Given this list of marker genes Dleu2, Frg2f1 (NCBI Gene Id 433752), Ccdc159 (coiled-coil domain containing 159), Cetn2, Mir24-2 (microRNA 24-2), Tmem80, Cd164 (CD164 antigen), Zfp580, Dnajc10, Map3k7, Wdr70, Zfyve27, Kxd1 (NCBI Gene Id 97450), Oip5, 4933433G15Rik, Wdr25, Casp4, Atp6v0a4, Tex10, Pcyox1l, Neu2, Hpn, 2010016I18Rik, Ovca2, mt-Tn, Sac3d1, Adgrb1, Hnrnpul1, Gm37294, Kmt5c, Mob3b, Cd69, Kmt2c, Rela, Gm2453, Wdr77, Inpp5a, Bltp2, Zfp948, Axin2, Ifngr2, 0610038B21Rik, Rnf139, Map3k8, Kel, Gm25721, Dchs1, Kif23, Thap1, Adam5, Mrps18c, Pih1d1, Foxp1, Pigw, Gramd1a, Setd5, Nfam1, Ndufb9, Psme2, Fam221a, Rbck1, Rc3h1, Hadha, Stag3, Junb, Snhg8, Nox1, Cish, Msh3, Nlrp3, Selenok, 2010106C02Rik, Atp5f1c, Grk4, mt-Nd2, Anxa5, Tet2, Tbc1d1, Runx1, Plp2, Akr1b8, Pcdh7, Mir9-2, Odr4, Cdk5rap1, Ccdc66, Mir5130, Trp53, Tanc2, Usp19, mt-Tl1, Srebf1, Gm14656, Vps35l, Grin1, Laptm4b, 1700066M21Rik, Prex1, Smim5, Plekhg1, Arhgap10, 1700084C06Rik, Cebpg, Mmel1, Pax7, D230022J07Rik, Gm11788, B3galnt2, Arhgef10l, Myl4, Adh6b, Mgarp, Yy1, Mrpl44 (mitochondrial ribosomal protein L44), Mxd1, Irf2, Dennd4b, Hirip3, Smc4, Ccdc71, Gm8066, Hsd3b7, Nomo1, Tmem38a, Haus2, Pusl1, Mylip, Rsu1, Chpt1, B4galt6, Slc30a7, Abl1, Cnih4 (cornichon family AMPA receptor auxiliary protein 4), Pik3r5 (NCBI Gene Id 320207), Nsun6, Nfil3, Stk11ip, Gm22148, 5830454E08Rik, Ilk, Gtf2i, Fam110a, Gm26419, Gm10605, Rab28, Cfap126, Hivep1, Smg1, Sh2b3, Wiz, Cystm1, Sf3b1, Odf2, Tmem168, E2f3, Gripap1, Kcnab1, Gm12764, Nkx1-2, Atxn2l, Vim, Zbtb26, Barhl1, Dab2, Zmiz2 (zinc finger, MIZ-type containing 2), Slf2, Lrrfip1, Fcrl5, Pop1, Nek11, Jak2, Bod1l (biorientation of chromosomes in cell division 1-like), 0610043K17Rik, Fbxo46, Pigv, mt-Th, Nme5 (NCBI Gene Id 75533), Hspb7, Usp49, Snord55, Mif4gd, Rock1, Csrnp1, Rrp1b, Fubp3, Ankrd13a, Scrn3, Kmt5b, Ppie, Dgkz, Gna15, Pomt1, Adgre1, Ccl9, Wrap53, Stk10, 2410006H16Rik (NCBI Gene Id 69221), Gm15283, Xntrpc, 4933405D12Rik, Katna1, Rasa1, Fam20c, Slc49a4, Nkapd1, Paxip1, Chfr, Stau1, Bcl2l1, Ttc39b, Taf3 (TATA-box binding protein associated factor 3), Hsp90ab1, Ripk2, Afg3l1, Plec, mt-Tq, Atl2, Ddx1, Ccl5, Ppp1r21, Gm11527, Rras, Lxn, Rbm4b, Gm5475, Il16, mt-Co2, Cct4, Gosr2, Wt1, Slc39a4, Cul1, Ascc3, Gm6410, Gm26756, Ptges, Dcun1d4, Efcab14, Pabpc1 (NCBI Gene Id 18458), Hexb, Mfsd13b, Nab1, Etv1, Pced1a, mt-Ty, C3, Rdx, Ubxn2a, Ccr3, Arpin, Mdm4, Gm2673, Pnrc1, Cep120, Nod2, Ahctf1, Nmd3, Mnt, Iscu, Dedd, A630072M18Rik, Mir9-2hg, Plcg2, Inpp5k, Rn7s6, Nfkbiz, AA386476, Tmem164, Mri1, Prelid3a, Ctdspl2 (NCBI Gene Id 51895), Prr12, Pigg, Adam9, Prmt5, Nsl1 (NCBI Gene Id 98359), Gorasp2, Hipk3, Ift81, Rab40c, Armc10, Mapre2, Hyal2 (hyaluronoglucosaminidase 2), Ddx5, Agk, Sall2, Satb2, Pea15a, Dusp13b, Zfp367, Gm12508, Zfp429, Arhgef1, Chchd1, Irf1, Serf2, D2hgdh, Map7d1, Sufu, Pwwp2a, Gm11476, Parp4, Traf3, Snora24, 2900052L18Rik, Sqle, Zfp593, Fndc4, Or6c208, Rasgrp4, Gm10699, mt-Ta, Ddhd1, Slc30a1, Capg, Sirt2, Lasp1, Cep68, Pa2g4, Gpr155, Il1rn, Fermt1, Scp2, Eif1ad, Acot7, Gm10575, Sfi1, Tec, Agps, Cyp4v3, Il2rg, Mir7653, Sertad2, Rps12l1, Gm15290, Nr3c1, Tex264, Zbtb21, Zkscan17, Armc9, Cnksr3, Uap1, Arap1 (NCBI Gene Id 69710), Tfe3, Stard10 (StAR related lipid transfer domain containing 10), Slain2, Pag1, S100a10, Zranb3, Tm2d2, Rap2c, mt-Ti, Il3ra, Gm7461, Pnrc2, Ankrd33b, Gatad1, Efcab9, Sirt6, Ccny, Gpr19, 4930558J18Rik, AA474408, Lgals8, 1700055D18Rik, Nptn, Wdr4, Sdc4, Rhog, Cntnap1, Rarg, Igkv13-84, Alcam, Tnip1, Rlf, Cdc20, Serhl, Als2cl, Slc25a10, Flvcr1, Gm2566, Ggnbp2, Htra2, Pgap3, Togaram2, Chd7, Ing2, Sys1, Vwa8, Necap2, Larp1b, Grk2, Ctnna3, Smad2, Ralgds, Rpsa, Gpd2, Mir193a, Sucnr1, Gm16527, Zcchc4, Tnfsf13b, Slc1a2, Dym, Ttc33, Ttc9c, Btd, Tradd, Nrbf2, Tagap, Nfyc, Aff1, Ino80e, 1110020A21Rik, Cd44, Ago1, Rimklb, Nfkbie, Gnb1, mt-Tl2 (mitochondrially encoded tRNA leucine 2), Saxo2, Atg10, Gm12791, Ppp1r37, Lacc1 (laccase domain containing 1), Baz1b, Creld2, Ctu2, Map2k2, Epb42, Itpkc, Endod1, Gpr132, Slc35a3, Cds1, Traf1, Tmed1, Rab11fip5, Actr3, Ddx55, Ascc2, Ssb, Mms19, Ugcg, Ifrd1, Gipc1, Eif4a1, Birc3, 1810053B23Rik, Itga2b, Pou2f1, Ccdc6, Ssh2, Tmem135, Jph4, Twf2, Map1b, Ubp1, Arhgef2, Gpbp1, Irgm1, Cdk14, Tcirg1, Rabgap1, Clock, 4632411P08Rik, Tbck, Snd1, Kansl1, Tpr (translocated promoter region, nuclear basket protein), Uspl1 (NCBI Gene Id 231915), Sdhc, Grsf1, Resp18, Arfgap3, Ints12, Ccl3, Rps27l, Nusap1, Hbp1, Trappc8, Cdc42, 4933439C10Rik, Smoc1, Rdm1, Foxd2os, Abcb6, Akr1c12 (aldo-keto reductase family 1, member C12), Gm5106, Rpl22, Tigd2, Ctsa, Boll, Tnfaip3, Dut, Actrt3, Rpa2, Hnrnpa2b1 (heterogeneous nuclear ribonucleoprotein A2/B1), Myo19, Hadhb, Zbtb6, Pcid2, Pik3r1, Gpr85 (NCBI Gene Id 72866), Ranbp10, Snord49a, Zmiz1os1, Cfap77, Clec4a1, 1810037I17Rik, Dusp3, Rpl14-ps1, Ank1 (NCBI Gene Id 11733), Zbtb25, Rmrp, Ttc17, Enc1, Apba3, B2m, Bin1, Rcbtb2, Ptprj, Zeb1 (zinc finger E-box binding homeobox 1), Rgl1, Grk5, Camkk2, Nfkbid (NCBI Gene Id 243910), Akt2, Wee1, Adcy7, Srcap, Rsl1, Cebpa, Elf2, Gm16016, Golm1, Ehd1 (NCBI Gene Id 13660), Tor1aip1, Gm25541, Stom, 1700108F19Rik, Ttc19, Slc15a3, H2-T22, Map3k12, Asns, Gm14692, Sms, Rhoc, Bach1, Slc11a1, Rhoa, Bnip3, Hspbap1, Slamf9, Nup205, Ppm1g (protein phosphatase 1G (formerly 2C), magnesium-dependent, gamma isoform), Usp15, Jpt1, Pbx3, Gm12500, 9130017K11Rik, Erc1, Sfr1, Furin, 5430400D12Rik, Frmd4b, Dennd4a, Gm15663, Pafah1b3, Cenpo, Mir5131, Itga4, Asxl1, Mllt6, Atox1, 4930412F09Rik, Zc3h12c, Ube2d3, Ccdc122, Coq8a, Sugt1, Fchsd2, Pwwp2b, Spaca6, Zfp40, Gm10244, Lzts2, Cbx8, Txn2, Gm12509, Zc3h10, Klc4, Mir1938, Atp6v1b2, Ebi3, 2310010J17Rik, Sfpq, Zfp768, Hjurp, Capzb, E130102H24Rik, Lgr4, Lancl2, Caprin1, Gatd1, Artn, Luzp1, Urah, Gm15880, Dbp, Upp1, Smarcd3, Gm15559, Lpin2, Fam3c, Jdp2, Akt3, Cxcl11, Rrad, Cul3, Itga5, Calcr, Sema4d, Edem3, Xbp1, Rel, Atpaf2, Dusp2, Mir449c, Capn7, Ago3, Brat1, Phip, Oas1h, Ntan1, Notch2, Ramac, Epb41, Sdc1, Gm15545, Psmf1, Il6st, Jade2, Mis18bp1, Trbv12-1, Rhbdd2, Degs1, Edf1, St7, Relb (avian reticuloendotheliosis viral (v-rel) oncogene related B), Prickle3, Rab11fip4, Hspa5, Eif4h, Nfx1, Gm9889 (NCBI Gene Id 791369), Gbp5, Slc29a2, A530072M11Rik, Picalm, Iqch, Mtmr6, Sde2, Gm14703, Amz2 (NCBI Gene Id 13929), Ubac2, Nme1, Zbtb7b, Ptgr2, Foxh1, Tlr2, Gstcd, Nrf1, Msh6, Pax6, Tmem184b, Ier2, Gm19721, D930030I03Rik, 1810062G17Rik, Pierce2, Meig1, Dtnb, 2310044K18Rik, Pacc1 (proton activated chloride channel 1), Tra2a, Cux1, Tatdn1, Apobr, Yipf3, Mmp9, Pacsin2, Tiparp, Gm16712, Wrnip1, Taok3, Cimap1b, Cimap2, Csnk1g1, Srgap2, Sp100, Ppt1, Niban2, Dhfr, Zc3h12a, Nsdhl, Wdtc1, Aste1, Hip1r, Creb1, Fmo4, Gm11769, Zfp143, Fhad1, Slc12a4, Cdh4 (cadherin 4), Dock6 (NCBI Gene Id 76780), Rad18, Mrps22, Zmynd12, Rnf121, Rrp8, Eef1b2, Cxcl1, Gm7008, Gm22675 (NCBI Gene Id 115489578), Echs1, Bmi1, Fau-ps2, 4732471J01Rik, Sart3, mt-Tw, Rspry1 (NCBI Gene Id 67610), Synpo, Tsn, Aldh16a1, 1700058P15Rik, Neil2, Gm14455, Insyn2b, Or8b8, Pdss1, 9130230L23Rik (RIKEN cDNA 9130230L23 gene), Nr2f6, Aagab, Ern1, Cxcl10, Akap10, Cnot10, mt-Td, Mars1, Six5, Golga5, Capza2, Moap1, Zfp280d, Jpx, Tsc22d4, Hnrnph3, Polr1c, Slc25a19, Ube2q1, Mov10, Kat8, Nfkbib, Phldb1 (pleckstrin homology like domain, family B, member 1), Prkar1a, Or7g31, 2010320M18Rik, Acp5, Tm9sf3, Arid1a, Cd151, Prkacb, Eva1b, Far1, Clta, Mlc1 (NCBI Gene Id 170790), Esyt2, Gm22813, Vapa, Slc25a54, Arl5c, Tob2, Ifrd2, Mir210, Nudt9, Gm4189, Atf7ip, Brd9, Nadk (NAD kinase), Ppp3ca, Pias3, Il27ra, Dclre1c, Sema4a, Poglut1, Cep95, Atrip, Kifc3, Mir762, Ccr10, Ufl1, Rps2, Acap3, Exd1, C330022C24Rik, Ddx54, Ccdc107, Dusp5, Samd4, Gbp6, Utp3, Zbtb3, Usp25, Gm29257, S1pr1, Ubl7, Map4, Gpd1l, Fosl2, Rps8, Bbc3, BC049739, Troap, Chrac1, Wdr26, Zbtb10, Ube2h, Prkcd, Asb1, Aup1, Polr2a, Rad54l2, Arhgap12, Map4k4, Hmgb1, Epas1 (NCBI Gene Id 13819), Zfp1006, Cd83, Tmie, Cdk12, Tbc1d22b, Pwp1, Pik3r2, Denr, Glt8d2, Ampd3, Morf4l1, Pus3, Flywch2, Cdc14a, Tmcc1, Ptpn3, mt-Tm, BC005537, 4930515G01Rik (RIKEN cDNA 4930515G01 gene), Tnip3, Tsc1, Srd5a3, Sik3, Krt19, Ulbp3, Rnf38, Sesn2, Gm7467, Mir6236, Arhgef19, Eif1b, H4c1, Gm24524, Rapgef1, Tsnax, Bmal1, Sh3glb1, Birc5, Capn5, Tpk1, Cyp7a1, Cdc20b, Ift80, Trappc3, Afg1l, Alas1, Rps5, Wars1, Akap7, Lrp11, Slc39a13, Thnsl1, Mir7075, Gm26330, Gpr84, Nenf, Snora64, Olfr1235-ps1, Tmco6, Bpi, Ptrhd1, Rgs19, Ptprs, Cnrip1, 1700066B17Rik, Atp9b, Elp1, Enoph1, Zic4, Gm13610, Tas2r140, Kctd12, R3hdm1, Wdfy1, Mllt1, Ppp2r3a, Gm43838, Irf5, Naa10, Stk11, Ccr9 (C-C motif chemokine receptor 9), Ccpg1, Ddx59, Tnfaip2, Pja2, Ubr4, Trim29, Gt(ROSA)26Sor, Crybg3, Mrpl17, Snord49b, Milr1, 1810021B22Rik, Gm15411, Sfswap, Aimp1, Gm15972, Mgat4a, Adck1, Stxbp1, Itgb5, Ampd2, Rita1, Pycard, Stx11, Stat3, Rnaseh2b (NCBI Gene Id 68517), Mkrn1, Gm15564, Ccdc9, Prkag1, Clk4, A930006K02Rik, Gbe1, C130046K22Rik, Hif1a, Acin1, Ipo5, Fuz, Ap2a2, Eps15, Unc119, Relt, Ptpn2, Zbtb1, Gfi1b, Gm13010, Tpbg, Rbm19, Usp42, Taco1, Klhdc8b, Il4ra, Ptpra, Bcl10, Prpf40a, Ppcs, Trmt10a, Zfp608, Ark2n, Hexa, Yipf2, Ypel5 (yippee like 5), 4930583K01Rik, Trabd, Gm12359, Flii, Sptan1, Atosa (NCBI Gene Id 70761), Ift88, Ino80d, Gm567, Mttp, Xiap, Sox6, Fzr1, Tnpo1, Ncoa4, Zfp800, Slc30a3, Pde4a, Jmjd1c, Manbal, 2810414N06Rik, Ndufv3, Tssk6, Or10ad1b, Grid2ip, Fbxl2, Zmym6, Esco1, Plekhf2, Rgs9, Bcorl1, Ccrl2, Gm9920, Memo1, Manba, Ubtd1, Ikbke, Mef2c (NCBI Gene Id 71350), Gm6283, Clpp, Gm16675, Erp29, Dclre1a, Gm11613, Polr2e, Rab6a, Dhx29, Snx5, Smpx, Abca1, Ctbp1, Gnb3, Gm24922, Ripor2, Setx, Tmem217, Trip4, Gm14221, Svil, Lmna, Mpc1 (mitochondrial pyruvate carrier 1), 1700113B19Rik, Sat2, Plau, Gpatch8, Gm11952, Neurl3 (NCBI Gene Id 76530), Gmeb1, Cd40, Terf2, 1700113A16Rik, Lyplal1, Ube2m, Nfe2l1, Micu1, Zfp287, Uck2, Nipsnap3b, Kpna4, Pde8a, Tor1aip2, Tufm, Ube2e3, Hmg20a, Csf1, Phf8, Gm26812, Nudt1 (NCBI Gene Id 17766), Frmpd3, Lmbrd1, Esrra, Tor4a, Rab34, Meis1, Xndc1, Gm4890, Nup153, Ticam2, Zdhhc15, Coasy, Nop14 (NCBI Gene Id 75416), Smad5, Zfp91, Sec24a, Tmem19, Herc3, Ube2e2, Prxl2c, Ltbr, Cbx3, mt-Nd1, Hgf, Nrp2, 2500004C02Rik (RIKEN cDNA 2500004C02 gene), Gm13270, Acox3 (NCBI Gene Id 80911, acyl-Coenzyme A oxidase 3, pristanoyl), Mrpl2, Pacsin3, Gm15850, Ino80dos, Dennd1a, Nlrp10, Rraga, Ppp4r3b, Mars2, Bloc1s1 (NCBI Gene Id 14533), Slc36a3os, Amfr, Nfatc1 (nuclear factor of activated T cells, cytoplasmic, calcineurin dependent 1), Stard9, Nvl, Ptar1, 4632428C04Rik, Adgrg6, Pfkfb4, Prdm4, Rab3ip, Arl6ip6, Gbp9, Nudt17, Tln1, Clic4, Rev3l, 9530034E10Rik, Csgalnact2, Etv5, N4bp2l1, Limd2, Smim7, Echdc3, Gm15417, Luc7l, Il27, Psme1, Sun2, C1qc, mt-Cytb, Emsy, Mydgf, Ifi30, Srrm2, Cox18, Rin2, Rrp9, Plppr2, Ap1s2, Skil, Tcf4, Mir425, Mir23a, Jup, Urb1 (NCBI Gene Id 76006), Cfp, Pnpla2 (patatin-like phospholipase domain containing 2), Cir1, Ist1, Gmcl1, Htra1, Sgo1, Helq, Nlk, Arfgef3, Pou2f2, Rida, Chp1, 1700088E04Rik, Dap, Arf4 (ADP-ribosylation factor 4), Kcnq5, Mmp2, Spice1, Lrrc57, Lrrk1, B3gntl1, Gnaq, Gnb2, Bhlhe40, Mtrex, Dnajc12, Mir27a, Tcea2, Gadd45b, Sec23b, Specc1, Slc17a5, Tlr9, Col18a1, Adora2b, Ppp6r1, Gin1, Ganc, Zbtb20, Dbn1 (NCBI Gene Id 56320), Rnf111, Bms1, Kif5c, Gclm, Pdlim5, 1700065D16Rik, Tsnaxip1, Pde4b, Nfkbia, Cdca7, Rad52, Cd70, Pkd2l1, Rps6 (ribosomal protein S6), Cntrl, Xpo6, Tsc22d1, Parp3, Septin9 (NCBI Gene Id 53860), Polr3e, Pcnx4, Pan3, Syncrip (synaptotagmin binding, cytoplasmic RNA interacting protein), Prkci, Gpx4, Tceal7, Aldoa, Azin1, Otud4, Cblb, Tmem87b, 2500002B13Rik, Mafa, N4bp3, Myh9, Mthfd1l, Raph1 (Ras association (RalGDS/AF-6) and pleckstrin homology domains 1), Arl5b, Nap1l4, Nfkb1, Cln3, Egln2, Mir7009, St6galnac6 (NCBI Gene Id 50935), H1f10, Cpsf4, Cacna1a, Rabgef1, Pheta1, Tank, Dhx9, Socs3, Kctd18, Sipa1l3, Sh3yl1, Ighv1-45, Zdhhc20, Tra2b, Nfkb2, Osm, Mcub, Rtel1, Bcl7c, Chd9, Kcp, Gm16685, Gm24393, Atp6ap2, Kat6a, Zzz3, Dennd10, Lrrc59 (leucine rich repeat containing 59), Mt1, mt-Tc, Atp2b1, Vamp4, Mrm1 (mitochondrial rRNA methyltransferase 1), Irak1bp1, Ankhd1, Dmtf1, Foxd2, Stau2, Rdh5, Spred1, Sin3a, Exosc7, Tgif1, Ep400 (E1A binding protein p400), Paqr3, Pfkfb2, Socs1 (NCBI Gene Id 12703), Chct1, Cnnm4, Uqcr11, Trip13, Vcan, Klhl25, Gm6658, Lrrc52, Cxcl2, Cfap44, Sod1, Rnf2, Gsdmd, Hnrnpdl, Fnbp4, Arid5a, Kbtbd2, Gm34086, 4632404H12Rik, Smarca2 (NCBI Gene Id 67155), Nr1d2, Chd2, Rcsd1, Slc44a3, Washc5, Nr1d1, Ifnar1 (interferon (alpha and beta) receptor 1, NCBI Gene Id 15975), Gm20652, Pgghg, Ntn1, Rfc1, Gm10602, Chordc1, Plk4, Srsf4, Mrpl12, Mir7011, Agap2, Pde4c, 4930539J05Rik, Psme3ip1, Snora78, AU016765, Haus1, Ptpn6, Cul4a, Klhl12, Atp5pb, Adrb2, 9130401M01Rik (RIKEN cDNA 9130401M01 gene), Irak2, Gas7, Fam20b (FAM20B, glycosaminoglycan xylosylkinase), Dvl1, Casc3, Pum2, Tmem116, Togaram1, Mad1l1, Pih1d2, Deaf1, Adamts17, Fmnl1, Tspan4, Arl6ip4, Pmpcb, Tor3a, Tet3, Ntpcr, Tmem42, Alkbh5, Cd93, Pan2, Ulk1, Gm4755, Nos2, Thap6, Tcta, Erich1, Zdhhc3, Tgfb1, Slc26a6, Tlcd1, Zfp410, Ddb1, Gm8357, 2810454H06Rik, Dusp1, Dstyk, Plek, Septin8, Alg12, Gm26766, Ythdf2, Nqo2, Tnks2, Snhg9, Wwox, Gpsm1, Got1, Gm12992, Slc9a8, Rbpj, Npm2, Mpzl1, Mcemp1, Gm13421, Atosb, Cyba, Rasgef1a, Foxj3, Ttk, Gm9917, Tatdn3 (NCBI Gene Id 68972), Prnd, Rcl1 (RNA terminal phosphate cyclase-like 1), Mtf2, Mfsd13a (major facilitator superfamily domain containing 13a), Kremen1, Kctd21, Ccnl1, Ap1s3, Pogk, Gm26397 (predicted gene, 26397), Fas, Ap3s2, mt-Ts2, Sirt1, Cd74, Il12rb2, Shc1, mt-Co1, Anp32a, Pprc1, Mpz, Pde3b, Psma6, Zfp446, Jund, Atg16l2, Gltp, Entpd8, Fndc3b, Gm16576, Sap30, Zfand2a, Cyfip1, Kctd11, Znrf1, H1f8, Trex1, Bzw1, Frs3, Eno2, Srsf9, Rtp4, Izumo1, Ppm1b, Ttl, Cyren, Ubxn11, Rps19bp1, Tnks1bp1, Ext1, Esr1, Rbm39, Klhl28, Esrp2 (epithelial splicing regulatory protein 2), Ago4, Rps6ka1 (NCBI Gene Id 230803), Creb3, Grap, Irak1, Rbm34, Copg2, mt-Nd5, Ptbp3, Grk3, Pecam1, Rap1gds1, Chkb, Mm2pr, Immp2l, Ctcflos, Bcl3, Gmnn, 1700092C17Rik, Pcmt1, Trim33, Ly96, Mbd2, Zfp799, Enkur, Serpinb9, Prickle4, Atr, Gid4, Usp35 (NCBI Gene Id 381901), Mast4, Lgals9, S100a3, Arpc5, Gm6034, Gm15165, Tkfc, Mdn1, Hnrnpr, Pgp, Mob4, Olr1, Gm11936, Upf3a, Mir155, Fbxl3, D930048N14Rik, Tas1r1, Mrfap1, Cdk17, Proscos, Mapk6, Tjap1, Pdzk1ip1, Rtf2, Pxn, Cc2d1b, Kcnn2, Mrps33 (NCBI Gene Id 14548), Gm11836, Nol4l, Malt1, 2410002F23Rik, Nol9, Gmfg, Il4i1, Tada1, Smad3, Aebp2, Birc6, 6430571L13Rik, Gabpb2, E130307A14Rik, n-R5s88 (nuclear encoded rRNA 5S 88), Map4k2, Tnfaip8l1, Xrn2, Ky, Fos, Mtmr14, Acer2, Zfp866, Tarbp2, Usp43, here is a description of the gene set: from publication Yevshin I, Sharipov R, Kolmykov S, Kondrakhin Y, Kolpakov F (PMID 30445619) Mouse Gene Set: NFKB1_TARGET_GENES Genes containing one or more binding sites for (Nfkb1) in their promoter regions (TSS -1000,+100 bp) as identified by GTRD version 20.06 ChIP-seq harmonization. studied in species Mus musculus